The following is a description of a gene set: Genes predicted to be targets of miRBase v22 microRNA hsa-miR-939-3p in miRDB v6.0 with MirTarget v4 prediction scores > 80 (high confidence targets). from publication Chen Y, Wang X (PMID 31504780) studied in species Homo sapiens Human Gene Set: MIR939_3P, and this is the list of marker genes: PHLDB2, PHF1, MGAT5B, ANKRD6, UBE2QL1, CAMK2B, CHML, CBLN2, AGBL5, FAM53C, ZNF500, GFAP, SLC26A9, TBC1D20 (NCBI Gene Id 170488), AKAP8, TNFAIP8L1, DENND3, ITGA5, SFMBT2, KCNJ5-AS1, OXSR1, SMIM12, AARS2, DCTN5, SOX10, TGFBR1, TFE3, SLC43A2, ATXN7L3, ITGA9, S100A7A, MED22 (NCBI Gene Id 90955), VEGFA, BTRC, FBXO27 (F-box protein 27), TOR1AIP2, PLXDC2 (plexin domain containing 2), HIF1AN, SLC26A1, AWAT1, ABCA3, THBS3, ZNF346, LASP1, G6PC3, PIP5K1C, TBC1D13, ADK, CNOT9, MYCL, PLEKHG4B, DDA1, IL24, BACH2, AHRR, KCP (NCBI Gene Id 378173), CLDN9, FBXL16, B3GNT7, KPNA4, PHF24 (NCBI Gene Id 23349), VWA1, DIS3L2, SUSD6, MTCL2, DUSP14, CSDC2, DEPDC5, SLC6A17, EXOC2, ANP32A, ELAVL1, SLC2A8, KPNA6, PLEKHF1, TENM4, MED29, TUBGCP5, COL5A1, KCNC4, SLC5A1, SPTLC2, DMTN, GNAL, FAM168A, MDGA1, B3GAT3, DLGAP3, C17orf58, RHOC, DLX4, PLCB1, ALS2CL, PSMF1, USF1, HEMK1, MPP2, ORAI2, TNFRSF10D, ELMO2, RAB5B, BACE1, TMOD1, WDPCP, CRTC1, AHCYL2, SHISA7, PHF2, POLDIP2, CSRNP1, WIPI2, SPTLC1, PIRT, OSR2, ATG7, VMAC, ZDHHC3, SPN, HCAR1, GDPD5, LOXL3, DCAF7, NALF2, HTR3B, ABCG4, SNN, PLPBP, PRCC, B3GNT3, EGFR, RNF44, LRRC15, PRR14L, H6PD, DRAXIN, RPS6KA1, TBC1D16, PIK3R1, PFDN1, MTF1, ADCY2, AMACR, MITF, FAM227A, GPR173, CISH, CRB3, STK4